The following is a description of a gene set: Genes down-regulated in E12.5 forelimb buds with POR knockout. Cytochrome P450 oxidoreductase (POR) is the obligate electron donor for all microsomal cytochrome P450 enzymes, which catalyze the metabolism of a wide spectrum of xenobiotic and endobiotic compounds. Point mutations in POR have been found recently in patients with Antley-Bixler-like syndrome, which includes limb skeletal defects. In order to study P450 function during limb and skeletal development, we deleted POR specifically in mouse limb bud mesenchyme. Forelimbs and hind limbs in conditional knockout (CKO) mice were short with thin skeletal elements and fused joints. POR deletion occurred earlier in forelimbs than in hind limbs, leading additionally to soft tissue syndactyly and loss of wrist elements and phalanges due to changes in growth, cell death, and skeletal segmentation. Transcriptional analysis of E12.5 mouse forelimb buds demonstrated the expression of P450s involved in retinoic acid, cholesterol, and arachidonic acid metabolism. Biochemical analysis of CKO limbs confirmed retinoic acid excess. In CKO limbs, expression of genes throughout the whole cholesterol biosynthetic pathway was upregulated, and cholesterol deficiency can explain most aspects of the phenotype. Thus, cellular POR-dependent cholesterol synthesis is essential during limb and skeletal development. Modulation of P450 activity could contribute to susceptibility of the embryo and developing organs to teratogenesis. Human Gene Set: SCHMIDT_POR_TARGETS_IN_LIMB_BUD_DN species: Mus musculus from publication Schmidt K, Hughes C, Chudek JA, Goodyear SR, Aspden RM, Talbot R, Gundersen TE, Blomhoff R, Henderson C, Wolf CR, Tickle C (PMID 19273610), and this is the list of marker genes: NAIP (NCBI Gene Id 82693), CPA3, CHRNA5, ABCA1, IFITM1, ALDH1A2, CHMP4C, MSX2